The following is a description of a gene set: Metacarpophalangeal joint contracture A chronic loss of joint motion in metacarpophalangeal joints due to structural changes in muscle, tendons, ligaments, or skin that prevents normal movement. Human Gene Set: HP_METACARPOPHALANGEAL_JOINT_CONTRACTURE studied in species Homo sapiens, and this is the list of marker genes: ASXL1, RNF13, FLNA, MAP3K7, MYL11